Given this list of marker genes Adss2, Gria1, Cps1, Kcnq3, Slc1a1, Kcnc2, Ass1, here is a description of the gene set: Mouse Gene Set: GOBP_RESPONSE_TO_AMMONIUM_ION Any process that results in a change in state or activity of a cell or an organism (in terms of movement, secretion, enzyme production, gene expression, etc.) as a result of an ammonium stimulus. species: Mus musculus